Given this list of marker genes Ano5, Ano9, Ano1, Ano6, Clca3a2, Ano7, Ano8, Ano2, Ano10, Clca3b, Ttyh3, Clca2, Ttyh1 (NCBI Gene Id 80467), Ano4, Ano3, Clca1, Ttyh2, Clca4a, Best3, Clca3a1 (NCBI Gene Id 12722), Nmur2, Clca4b, Best1, here is a description of the gene set: Enables the transmembrane transfer of chloride by a channel that opens in response to stimulus by a calcium ion or ions. Transport by a channel involves catalysis of facilitated diffusion of a solute (by an energy-independent process) involving passage through a transmembrane aqueous pore or channel, without evidence for a carrier-mediated mechanism. Mouse Gene Set: GOMF_INTRACELLULARLY_CALCIUM_GATED_CHLORIDE_CHANNEL_ACTIVITY species: Mus musculus